Given this list of marker genes Hes1, Sox4, Lox, Tgfb2, Hey2, here is a description of the gene set: The progression of the ascending aorta over time, from its initial formation to the mature structure. The ascending aorta is the portion of the aorta in a two-pass circulatory system that lies between the heart and the arch of aorta. In a two-pass circulatory system blood passes twice through the heart to supply the body once. Mouse Gene Set: GOBP_ASCENDING_AORTA_DEVELOPMENT studied in species Mus musculus